Given this list of marker genes C5orf15, RPL22, ECPAS, DIAPH2, OGFOD3, LRP8, TRMT5, H4C3 (NCBI Gene Id 8364), SREK1IP1 (NCBI Gene Id 285672), MRPL58 (NCBI Gene Id 3396), SUCLG2, EIF2D, PPP2R5C, NUCKS1, KAT8, HDGF, HNRNPA3, PAPOLG, NDUFC1, PFAS, GOSR1, ARHGEF9, MAP2K6, TOM1L1, TBC1D5, HSPBP1, APOOL, NFIB, DHFR, LSM7, KPNB1, MACROD1, NOP53, AP1G2, CIRBP, PGGT1B, SNHG32, REV1, PMS1, PPIE, MOB1A, GATB, NUDT3, MECP2, HDAC4, EIF2AK2, RBMX, SH3BGRL, CCNA2, FAM216A (NCBI Gene Id 29902), GOLPH3L, MYF5, ITGB3BP, C14orf93, RPL13A, PDCD2, RBM8A, ANP32B, LYRM4, ERP44, ATRAID, KIF15, PAICS, CTBS, SUPT3H, HMGB2, PAAF1, PMF1, LUZP2, CSTPP1, ATM, here is a description of the gene set: studied in species Homo sapiens Lung cancer is the leading cause of cancer-related deaths in the United States due, in large part, to the lack of early detection methods. Lung cancer arises from a complex series of genetic and epigenetic changes leading to uncontrolled cell growth and metastasis. Unlike genetic changes, epigenetic changes, such as DNA methylation and histone acetylation, are reversible with currently available pharmaceuticals and are early events in lung tumorigenesis detectable by non-invasive methods. In order to better understand how epigenetic changes contribute to lung cancer, and to identify new disease biomarkers, we combined pharmacologic inhibition of DNA methylation and histone deacetylation in non-small cell lung cancer (NSCLC) cell lines, with genome-wide expression profiling. Of the more than genes upregulated by these treatments, three of these, neuronatin, metallothionein 3 and cystatin E/M, were frequently hypermethylated and transcriptionally downregulated in NSCLC cell lines and tumors. Interestingly, four other genes, cylindromatosis, CD9, activating transcription factor 3 and oxytocin receptor, were dominantly regulated by histone deacetylation and were also frequently downregulated in lung tumors. The majority of these genes also suppressed NSCLC growth in culture when ectopically expressed. This study therefore reveals new putative NSCLC growth regulatory genes and epigenetic disease biomarkers that may enhance early detection strategies and serve as therapeutic targets. from publication Zhong S, Fields CR, Su N, Pan YX, Robertson KD (PMID 17043644) Genes down-regulated in 3 out of 4 NSCLC cell lines (non-small cell lung cancer) after treatment with azacitidine and TSA. Human Gene Set: ZHONG_RESPONSE_TO_AZACITIDINE_AND_TSA_DN